Given this list of marker genes CRTC1, SOD2, AGT, HCN1, TRPC5, here is a description of the gene set: Any process that modulates the frequency, rate or extent of membrane hyperpolarization. studied in species Homo sapiens Human Gene Set: GOBP_REGULATION_OF_MEMBRANE_HYPERPOLARIZATION